The following is a description of a gene set: Human Gene Set: HP_SCLEROSING_CHOLANGITIS Sclerosing cholangitis studied in species Homo sapiens Cholangitis associated with evident ductal fibrosis that develops as a consequence of long-standing bile duct inflammatory, obstruction, or ischemic injury; it can be obliterative or nonobliterative., and this is the list of marker genes: NRAS, RFX5, DCDC2, DOCK8, MAP2K1, KIF12, CD40LG, RFXAP, CLDN1, CIITA, RFXANK, ABCB4, BRAF, REL